Given this list of marker genes OPRM1, POMC, GNG2, GNG13, GNGT1, GNB1, GNA15, GNAQ, GNG8, GNG10, GNGT2, GNG5, GNB3, GNG12, GNG3, GNA11, GNB2, GNG7, GNA14, GNB4 (G protein subunit beta 4), PDYN, GNG4, GNG11 (NCBI Gene Id 2791), GNB5, here is a description of the gene set: Receptor activated heterotrimeric G proteins consist of the Galpha and the tightly associated Gbeta-gamma subunits. When a ligand binds to a G protein-coupled receptor, it stabilises a conformation with an high affinity for the G-protein bound to GDP. GDP is then exchanged for GTP on the Galpha subunit. This exchange triggers the dissociation of the Galpha subunit from the Gbeta-gamma dimer and the receptor. Galpha-GTP and Gbeta-gamma, can then modulate different signalling cascades and effector proteins, while the receptor is able to activate another G protein, resulting in an amplification cascade. The Galpha subunit will eventually hydrolyze the attached GTP to GDP by its inherent enzymatic activity, allowing it to reassociate with Gbeta-gamma and start a new cycle. Reactome Pathway: G-protein activation part of: Opioid Signalling species: Homo sapiens